The following is a description of a gene set: Any process that stops, prevents or reduces the frequency, rate or extent of steroid hormone secretion. studied in species Mus musculus Mouse Gene Set: GOBP_NEGATIVE_REGULATION_OF_STEROID_HORMONE_SECRETION, and this is the list of marker genes: Cry2, Nrg1, Kcnk9, Tspo, Ptpn11, Cry1